The following is a description of a gene set: Human Gene Set: GOMF_L_GLUTAMATE_TRANSMEMBRANE_TRANSPORTER_ACTIVITY studied in species Homo sapiens Enables the transfer of L-glutamate from one side of a membrane to the other. L-glutamate is the anion of 2-aminopentanedioic acid., and this is the list of marker genes: SLC1A6 (NCBI Gene Id 6511), SLC17A8, SLC1A7, SLC25A18, SLC7A11, SLC1A3, SLC17A6, SLC25A22, SLC25A13, SLC17A7, SLC1A2, SLC38A6, SLC25A12, SLC1A1